The following is a description of a gene set: Mouse Gene Set: GOBP_L_ALANINE_TRANSPORT The directed movement of L-alanine, the L-enantiomer of 2-aminopropanoic acid, into, out of or within a cell, or between cells, by means of some agent such as a transporter or pore. studied in species Mus musculus, and this is the list of marker genes: Slc38a4, Slc3a2, Slc36a4, Slc7a8, Slc38a3, Slc36a3, Slc36a2, Slc38a5, Slc36a1, Sfxn1, Slc1a4